Given this list of marker genes SERPINE1, ALPL, RAD51C, DLK1, IL6ST, WRN, ESCO2 (establishment of sister chromatid cohesion N-acetyltransferase 2), SLC35D1, GBA1, ALB, HOXA13, PHGDH, CLN8, SLC26A2, FGG, FGB, NSD2, CEP120 (NCBI Gene Id 153241), HSPG2, COL11A1, MUSK, TRIP11, LGI4, RMND1 (NCBI Gene Id 55005), RHD (NCBI Gene Id 6007), BIN1, JAK2, COL2A1, WT1, CENPF (centromere protein F), MTMR14, FGA, RHCE, PLXND1, OSTM1, SERPINC1, NSDHL, HYLS1, CALCRL, NLRP7, DNM2, THPO, GRIP1, MEG3, ZMPSTE24, MGP, NUP88, CEP55, MYF6, RNU4ATAC, REC114, FLNA, MPL, RHAG, GDF5, PTH1R, NEK8, FLNB (NCBI Gene Id 8413), ENG, FCGR3B, LBR, HBB, RTL1, POR, RYR1, PITX1, PLIN1, here is a description of the gene set: studied in species Homo sapiens Human Gene Set: HP_PRENATAL_DEATH Prenatal death Death of a fetus in the uterus.